Given this list of marker genes LPIN1, NEK6, VRK1, CDK1, PRKCB, PLK1, CTDNEP1, PRKCA, here is a description of the gene set: Human Gene Set: GOBP_MITOTIC_NUCLEAR_MEMBRANE_DISASSEMBLY species: Homo sapiens The mitotic cell cycle process in which the controlled partial or complete breakdown of the nuclear membranes during occurs during mitosis.